Given this list of marker genes GPHN, XDH (xanthine dehydrogenase), SUOX (sulfite oxidase), AOX1, MTARC2, MTARC1, here is a description of the gene set: studied in species Homo sapiens Human Gene Set: GOMF_MOLYBDOPTERIN_COFACTOR_BINDING Binding to a molybdopterin cofactor (Moco), essential for the catalytic activity of some enzymes, e.g. sulfite oxidase, xanthine dehydrogenase, and aldehyde oxidase. The cofactor consists of a mononuclear molybdenum (Mo-molybdopterin) or tungsten ion (W-molybdopterin) coordinated by one or two molybdopterin ligands.